Given this list of marker genes TNNI2, WDR6, ITIH3, DDX3Y, PDE1B, GCLC (glutamate-cysteine ligase catalytic subunit), ZC2HC1A, STARD7, BAG1, ASPHD1, HMG20B, LAMB2, MTRF1L, HIGD2A, KIF22, CDK10, CALCOCO2 (calcium binding and coiled-coil domain 2), C1orf54, RUSF1, TXNIP, FKBP1A, NME4, RNF103, KCNAB2, ZNF224, ATP1B1, SLC50A1, RBM5, KIAA0930, OSBPL7 (oxysterol binding protein like 7), ATP2B4 (NCBI Gene Id 54594), NDUFS2, COASY, KAT5, DECR1, CPNE1, ZXDC, TXN2, STK19, GPAA1, APEH, TKFC, LONP1, TTLL3, RAC3, CELF1, NCKIPSD, MEF2C, MEPCE, NDUFS3, EIF3K, ITGB3BP, SIRT7, EIF5, TOR1B, RAB14, GORASP1, HEXIM1, STK25, GTPBP1, PPIA, PRR4, TDRD3, TTC31, RNH1, VPS11, LIN7B (lin-7 homolog B, crumbs cell polarity complex component), TRIP6, ATP5F1A, COTL1, MAN2B1, HLA-DPB1, ALDOB, LSP1, SLC38A2, CPNE6, CD180, FGL2, LCAT, GPC4, ATP5MC3, TXNL4B, NRGN, SNRNP200, BSCL2, QTRT1, ENGASE, MRPL11, RPL39L, GLIPR1, RIC8A, DGAT1, TIPARP, IST1, HLA-DMB, PMEL, MAN2C1, ITPK1, XPC, ITIH4, FAM111A, OGFR, S100A13, RCBTB2, RASAL1, SLC25A6, ALPK1, BCAP31, TP53I3, NDUFA1, SDHAP1, CYP21A2, CFAP410, SHMT2, TRIM38, KLHL20, NSUN5P1, NUMA1, ERBB2, ATP5MG, MDFIC, ENDOG, FASTK, ME1, POLD4, SESN1, POLD1, DHRS9, SAFB2, AAAS, RPL13, APOC4, MAN2A2, GALK1, FABP3, GOSR1, HMOX2, GRM4, ALDH1A2, KPTN, ALCAM, APOBEC3G, MLYCD, TMEM80, GPATCH3, ACADS, PRRG4, MRPS18B, KDM5A, SMAD1, GSDMD, CRABP2, EXD3, ROBO3 (roundabout guidance receptor 3), TIMELESS, HSPA6, USP21, PMPCA, DCAF11, C6orf62, PRKRIP1, CD74, PRCP, TSC1, PEX19, ADGRE5, SERINC3, ITGB7, KHDC4, GPI, TIAM1, GZMB, CD9, CROCCP3, ZNF219, HMCES, CAPN1, ARHGDIG, TBC1D1, RPS3, SDHA, PPARG, EBP, WDR13, NAT8, ECSIT, SPATA20, EVL, MAN1B1, ARHGAP15, CEBPA, ACOXL, DEK, SND1, CCS (NCBI Gene Id 9973), FBXO11, PTPRA, SEC11A, CD52, here is a description of the gene set: studied in species Homo sapiens from publication Shinohara H, Behar M, Inoue K, Hiroshima M, Yasuda T, Nagashima T, Kimura S, Sanjo H, Maeda S, Yumoto N, Ki S, Akira S, Sako Y, Hoffmann A, Kurosaki T, Okada-Hatakeyama M (PMID 24833394) Genes up-regulated in B lymphocytes with MAP3K7 knockout: untreated versus anti IgM for 24h. The activation signaling of transcription factor nuclear factor-kB (NF-kB) plays central role for immune system. One of key kinase mediating this pathway is TAK1 in adaptive and innate immunity. However, role of TAK1 in B cell receptor signaling is still unclear. To know effects of TAK1-deletion on the gene expression induced by anti-IgM, we performed the time course analysis in comparison of wild type with TAK1-deleted splenic B cells. Human Gene Set: GSE41176_UNSTIM_VS_ANTI_IGM_STIM_TAK1_KO_BCELL_24H_UP